Given this list of marker genes Cd1d1, Cd1d2, Abcc1, Ap3d1, Ap3b1, here is a description of the gene set: The process in which an antigen-presenting cell expresses lipid antigen in association with an MHC class Ib protein complex on its cell surface, including lipid extraction, degradation, and transport steps for the lipid antigen both prior to and following assembly with the MHC protein complex. The lipid antigen may originate from an endogenous or exogenous source of lipid. Class Ib here refers to non-classical class I molecules, such as those of the CD1 family. Mouse Gene Set: GOBP_ANTIGEN_PROCESSING_AND_PRESENTATION_OF_LIPID_ANTIGEN_VIA_MHC_CLASS_IB species: Mus musculus